The following is a description of a gene set: Most cancer deaths are due to metastasis, and epithelial-to-mesenchymal transition (EMT) plays a central role in driving cancer cell metastasis. EMT is induced by different stimuli, leading to different signaling patterns and therapeutic responses. TGF_ is one of the best-studied drivers of EMT, and many drugs are available to target this signaling pathway. A comprehensive bioinformatics approach was employed to derive a signature for TGF_-induced EMT which can be used to score TGF_-driven EMT in cells and clinical specimens. Multiple datasets were used to derive the signature using three approaches: by integrating the datasets prior to identifying EMT genes, by first identifying EMT genes from individual datasets and then combining them using a meta-analysis (product of ranks) approach, and by combining inferences from the first two approaches. Genes up-regulated in the epithelial-mesenchymal transition (EMT) upon transforming growth factor beta (TGFb) stimulation derived from multiple datasets by integrating them. species: Homo sapiens from publication Foroutan M, Cursons J, Hediyeh-Zadeh S, Thompson EW, Davis MJ (PMID 28119430) Human Gene Set: FOROUTAN_INTEGRATED_TGFB_EMT_UP, and this is the list of marker genes: ITGA5, ALOX5AP, POSTN, ZNF365, COL4A1, TGFBI, JUNB, STC1, MYL9, MRC2, CDH11, COL5A2, PTHLH, SPARC, SERPINE1, DSE, COL7A1, LMCD1, DOCK4, VGLL3, TIMP2, MMP1, GLIPR1, COL4A2, NCF2, TNS1, GAL, DLC1, FBN1, BMPR2 (bone morphogenetic protein receptor type 2), TCF4, CCN2 (cellular communication network factor 2), PDGFC, SPOCK1, SACS, TGFB1, CALD1, TUFT1, SLC22A4, DIXDC1, NKX3-1, PTPRK, IGFBP7, MMP10, JAG1, IL11, GADD45B, XYLT1, EPHB2, FERMT2, COL3A1, HMOX1, LUM, ANGPTL4, NREP, FOXD1, MFAP2, KCNMA1, DACT1, ACKR3 (NCBI Gene Id 57007), NUAK1, IGFBP5, GASK1B, PODXL, CDK14, MN1, HTRA1, SLC26A2, PDLIM7, NT5E, JUN, HS3ST3A1, DHRS2, FSTL3, SRPX, GALNT10, SKIL, TP53I3, TNFAIP6, INHBA, ARHGEF40 (Rho guanine nucleotide exchange factor 40), TGFB1I1, WNT5B, PLEK2, SCG2, CHRNA9, MAF, TPM1, TGM2, ITGB3, SCG5, CRLF1, PID1, FN1 (fibronectin 1), AP1S2 (adaptor related protein complex 1 subunit sigma 2), TAGLN, GREM1 (gremlin 1, DAN family BMP antagonist), MMP2, COL6A3 (NCBI Gene Id 1293), SPHK1, FHOD3, WNT5A, SERPINE2, THBS1, ADAMTS6, COL5A1, GFPT2, VCAN, SLN, PMEPA1, ADAM19, HSF2BP, RGS4, HS3ST3B1, SNAI2, COL1A1, NEDD9, LOX, SMAD7, CDH2